The following is a description of a gene set: This event has been computationally inferred from an event that has been demonstrated in another species.<p>The inference is based on the homology mapping from PANTHER. Briefly, reactions for which all involved PhysicalEntities (in input, output and catalyst) have a mapped orthologue/paralogue (for complexes at least 75% of components must have a mapping) are inferred to the other species. studied in species Mus musculus electronically inferred by orthology from the curated human pathway Reactome Pathway: Abacavir transmembrane transport part of: Abacavir ADME, and this is the list of marker genes: Slc22a2, Slc22a3, Slc22a1